The following is a description of a gene set: Human Gene Set: GOBP_NEGATIVE_REGULATION_OF_AMINO_ACID_TRANSPORT Any process that stops, prevents, or reduces the frequency, rate or extent of the directed movement of amino acids into, out of or within a cell, or between cells, by means of some agent such as a transporter or pore. studied in species Homo sapiens, and this is the list of marker genes: PRKG1, GRM7, SLC43A1, TNF, ABAT, SLC43A2, ARL6IP5, RGS2, NPY5R, RGS4 (NCBI Gene Id 5999), LEP (leptin), ADORA1, TRH, GABBR1